Given this list of marker genes RBPJ, PIM1, SOX9, NACA, BMP10, SMAD4, here is a description of the gene set: species: Homo sapiens Any process that activates or increases the frequency, rate or extent of cell proliferation involved in heart morphogenesis. Human Gene Set: GOBP_POSITIVE_REGULATION_OF_CELL_PROLIFERATION_INVOLVED_IN_HEART_MORPHOGENESIS